Given this list of marker genes Tyw5, Casp2, Bpgm, Chchd6, Cdh24, here is a description of the gene set: from publication Cui A, Huang T, Li S, Ma A, Pérez JL, Sander C, Keskin DB, Wu CJ, Fraenkel E, Hacohen N (PMID 38057668) Mouse Gene Set: CUI_ILC_IFNL2_RESPONSE_UP Genes positively differentially expressed in cell type: ILC (innate lymphoid cell) upon treatment with cytokine: IFN-λ2 in mouse lymph nodes in vivo. Cytokines mediate cell-cell communication in the immune system and represent important therapeutic targets. A myriad of studies have highlighted their central role in immune function, yet we lack a global view of the cellular responses of each immune cell type to each cytokine. To address this gap, the authors created the Immune Dictionary, a compendium of single-cell transcriptomic profiles of more than 17 immune cell types in response to each of 86 cytokines (>1,400 cytokine-cell type combinations) in mouse lymph nodes in vivo. A cytokine-centric view of the dictionary revealed that most cytokines induce highly cell-type-specific responses. For example, the inflammatory cytokine interleukin-1β induces distinct gene programmes in almost every cell type. A cell-type-centric view of the dictionary identified more than 66 cytokine-driven cellular polarization states across immune cell types, including previously uncharacterized states such as an interleukin-18-induced polyfunctional natural killer cell state. studied in species Mus musculus